The following is a description of a gene set: Human Gene Set: GOBP_PROTEIN_DE_ADP_RIBOSYLATION The process of removing one or more ADP-ribose residues from a protein. species: Homo sapiens, and this is the list of marker genes: OARD1, MACROD1, MACROD2, ADPRHL1, ADPRS, ADPRH